Given this list of marker genes NR2E1, JAG1, HES1, PAX6, NOTCH1, FGF9, RBPJ, ASCL1, NODAL, HMGN1, MSX1, NKX6-3, DLL1, SERPINE2, here is a description of the gene set: Human Gene Set: GOBP_REGULATION_OF_DEVELOPMENT_HETEROCHRONIC studied in species Homo sapiens Any process that modulates the consistent predetermined time point at which an integrated living unit or organism progresses from an initial condition to a later condition and the rate at which this time point is reached.